The following is a description of a gene set: Binding to an immunoglobulin of an IgG isotype. species: Mus musculus Mouse Gene Set: GOMF_IGG_BINDING, and this is the list of marker genes: Umod, Pip, Fcgr1, Fcgr2b, Fcgrt, Fcer1g, Fcgr3, Fcgr4